The following is a description of a gene set: species: Homo sapiens Human Gene Set: GSE44649_NAIVE_VS_ACTIVATED_CD8_TCELL_MIR155_KO_DN Genes down-regulated in CD8 T cells with MIR155 knockout: resting versus activated. MicroRNA-155 (miR-155) is upregulated in primary effector CD8 T cells but is expressed at low amounts in naïve cells. Anti-viral CD8 T cell responses and viral clearance were impaired in miR-155 deficient (bic-/-) mice, and this defect was intrinsic to CD8 T cells, as adoptively transferred bic-/- CD8 T cells generated greatly reduced primary and memory responses during infection. To understand the mechanism by which miR-155 regulates CD8 T cell activation, we analyzed the gene expression profiles of naive and in vitro activated wild-type and bic-/- CD8 T cells. from publication Gracias DT, Stelekati E, Hope JL, Boesteanu AC, Doering TA, Norton J, Mueller YM, Fraietta JA, Wherry EJ, Turner M, Katsikis PD (PMID 23603793), and this is the list of marker genes: MYEF2 (NCBI Gene Id 56051), MELK, PLS3, ZFP36L1, KBTBD7, NKRF (NCBI Gene Id 55922), ATAD5, RREB1, PARP8 (NCBI Gene Id 79668), EFCAB7, RNFT1, CEP192, DZIP3, CERT1, PDE3B, RAB21, CSTF2, CCDC88A, RALGAPA1, NUP160, RIOK2, CNNM4, CD274, PDSS1, PGM3, GCA, USP45, ATP11A, RPE, USP38, DEPDC7 (NCBI Gene Id 91614), R3HDM1, GPM6B, TIRAP, DHODH, BRIX1, SAMTOR, MAN1A1, CNEP1R1, RAD51AP1, CEP70, KBTBD8, RASGRP3, PARP1, ADCY7, C1GALT1, RBM34, TRMT11, ZNHIT3 (NCBI Gene Id 9326), INTS6, SMIM3, GALNT11, MTFMT, SHPRH, SLC39A10, SIRT1, EPS8, RNF13, LIN54, HSDL2, SFT2D3, PRORP, AFF4, BDP1, RP2, AP1AR, C7orf25, SMARCAD1, DENND4C, FAM156A, ARHGAP6, MED23, BORA, SMURF2, PEX12, SNAPIN, LRIF1, RASAL2, IFIT1, KMT5B, ICAM2, ALG10, SCAI, WASL, RIF1, RND3, PRKAR2B, DPY19L4, CDYL, RNPC3, HEATR5B, ZFAND4, FBXO11, PANK3, KATNBL1, ARID2, NPAT, PDCL, GPR155, NUP205, DDX52 (DExD-box helicase 52), PLPP5, GPRASP3, FOXN2, CDK7, ITGAL, PKN2, CIAO2A, KIF9, ORC4 (NCBI Gene Id 5000), KLRD1, FBXL5, PRIM2, PAPOLG, MED14, SUCLG2, SLC14A1, YTHDC2, COG5, LIMS4, BTBD10, GNA13, ANKRD10, SLC30A6, TMED5, REL, DYM, ARID4B, TRNT1, ZFYVE16, SSC5D, NFS1, KIAA0586, MTMR6, ZNF654, PBRM1, SLC31A1, LRBA (LPS responsive beige-like anchor protein), BLZF1, SLC35E2B (NCBI Gene Id 728661), STRADB, NCBP2, TSPAN2, ARHGAP15, RIPOR2, METTL15, DCTN6, TPK1, C14orf28, ZFP62, GTF2A2 (NCBI Gene Id 2958), SLC19A2, ACVR2A, OSGIN2, AP5M1, KLHL20, RNLS, INTS12, RBMX, SLC25A40, ASF1B, SNORD89, ZBTB33, CLINT1, TBP, RPS6KA3, GRSF1, TMEM263, TRDMT1 (NCBI Gene Id 1787), SUCNR1, TTK, MYO5A, KIFBP, NVL, CCNE2, FLVCR1, CDC25C, RPS6KB2, FBXO3 (F-box protein 3), TULP4, SLAMF6, CHEK1, HAUS6, H2BC13, P2RY10, IRF4, ZNF546, TAF2, POLK, HACL1, GNPNAT1, CASP7, SPECC1, RFC5, CSGALNACT2 (NCBI Gene Id 55454), ZNF157, C18orf54, CREBL2, GABPA, TCERG1